Given this list of marker genes CNOT7, CNOT1, CNOT8, CNOT2, CNOT9, CNOT3, here is a description of the gene set: Human Gene Set: GOCC_CCR4_NOT_CORE_COMPLEX studied in species Homo sapiens The core of the CCR4-NOT complex. In Saccharomyces the CCR4-NOT core complex comprises Ccr4p, Caf1p, Caf40p, Caf130p, Not1p, Not2p, Not3p, Not4p, and Not5p.